The following is a description of a gene set: from publication Elo LL, Järvenpää H, Tuomela S, Raghav S, Ahlfors H, Laurila K, Gupta B, Lund RJ, Tahvanainen J, Hawkins RD, Oresic M, Lähdesmäki H, Rasool O, Rao KV, Aittokallio T, Lahesmaa R (PMID 20620947) Genes down-regulated in comparison of CD4 T cells treated with IL4 and anti-IL12 at 0.5 h versus those at 72 h. The aim of this dataset was to study in detail the transcription kinetics initiated by cytokine IL-4 in early differentiation of Th2 cells. species: Homo sapiens Human Gene Set: GSE17974_0.5H_VS_72H_IL4_AND_ANTI_IL12_ACT_CD4_TCELL_DN, and this is the list of marker genes: UHRF1, GPNMB, FUCA2 (alpha-L-fucosidase 2), PIMREG, PSMB2, KDM5B, PXMP4, CCNB1IP1, HMGA1 (NCBI Gene Id 3159), PRDX3, TMEM273, SKA3, F8, CD99 (CD99 molecule (Xg blood group)), ENOPH1, CCDC32, CD320, ACTG1, HNRNPC, PTGIS, PNPLA3, TRAIP, MELTF-AS1, BABAM2 (BRISC and BRCA1 A complex member 2), FXR1, LMNB2, SHMT1, ZNF775, TMEM120A, MRPL35, ZNF322P1, B3GNT2, DCAF15, ISCA2, NDUFS2, CAPG, TRIB3, MRPL51, ZNF672, CYB5B, KIFC1, RNASEH2A, KCNK5, CAMK2D, FOXM1, SLC29A1, ANKZF1, RNGTT, FBXO36, STXBP1, EIF2S1, ETHE1, EME1, STARD4, PAGR1, MSH6 (NCBI Gene Id 2956), ALCAM, NUDT2, ATP6V1F, GNPDA1, CDPF1, SNUPN, AHRR, COA6, ZSCAN22, HMGCL, SBF2-AS1, PFKM, KCNN4, RLN2, EHHADH, SIGLEC17P, RAN, CCNG1, METTL9, ACAT2, PAM (peptidylglycine alpha-amidating monooxygenase), POLQ, AGPAT2, MYCBP, NAA38, SLC39A8, ENO1, POLD3, SENP8, PALD1, LINC00467, UNG, HEXIM2, GLS2, STMN1, GBP2, STN1, RMI2, SURF4, ATP23, RCCD1, NCAPD3, DIAPH3, QPRT, ADK, RAD51C, CD109, TADA3, BDH1, STIP1, BTF3, EXOC3, MECR, RAD51D, CPNE2, TXN2, AJUBA, ACADVL (NCBI Gene Id 37), NUP107 (nucleoporin 107), CACNB3, HAUS4, MRPL12, LETMD1, ERI1, CAMK1, ACTB, TRIQK, NDUFAF1 (NADH:ubiquinone oxidoreductase complex assembly factor 1), LSM2, MGAT1, ETFB, KEAP1, TUBB, NCAPH (NCBI Gene Id 679), NPC1, IDH1, LINC02003, TMEM187, PAFAH1B3, MYO1B, GPANK1, TRAFD1, ADIPOR2, SQOR (sulfide quinone oxidoreductase), SQLE, MAP4K1, FANCA, FBXO4, GLO1, PPIL3, RPA3, EMC9, TNFRSF4, CTDSPL, ZNF589, ACOX3, INPP1, DHX32, CSRP2, ZKSCAN3, MRPS15, ILK, LINC01128, GLE1, CD58, CBLN3, ASTN2, SNAPIN, COA4, GEMIN6, PSMB8, NSD2, EYA3, PSMA5, FUT11, CNOT1, NCR3, RDX, DHRS1, RTL8C, AK3, C12orf76, LDHA, CDKL3, BRIP1, PAAF1, ELP5, HMGB3, HPDL, MAP1S, SARS2, CCNB1, PRKAG1, CYP51A1, RABEPK, JAK2, BCAT1, LGI1, CD9, MEOX1